The following is a description of a gene set: Human Gene Set: REACTOME_PHOSPHOLIPASE_C_MEDIATED_CASCADE_FGFR2 Phospholipase C-mediated cascade; FGFR2 species: Homo sapiens, and this is the list of marker genes: FGF17, FGF5, FGF10, FGF16, FGF1, FGF22, FGF2, FGF9, FGF18, PLCG1, FGF3, FGF20, FGF6, FGFR2, FGF8, FGF7, FGF4, FGF23